Given this list of marker genes NOPCHAP1, RUVBL2, RUVBL1, PIH1D1 (PIH1 domain containing 1), ZNHIT3, NUFIP1, SNU13, TAF9, PIH1D2, ZNHIT6, here is a description of the gene set: species: Homo sapiens The aggregation, arrangement and bonding together of proteins and a box C/D snoRNA to form a box C/D small nucleolar ribonucleoprotein (snoRNP) complex. Human Gene Set: GOBP_BOX_C_D_SNORNP_ASSEMBLY